The following is a description of a gene set: from publication Lee MS, Hanspers K, Barker CS, Korn AP, McCune JM (PMID 15210650) Human Gene Set: LEE_EARLY_T_LYMPHOCYTE_UP studied in species Homo sapiens Genes up-regulated at early stages of progenitor T lymphocyte maturation compared to the late stages. To develop a comprehensive catalogue of phenotypic and functional parameters of human CD4(+) T cell differentiation stages, we have performed microarray gene expression profiling on subpopulations of human thymocytes and circulating naive CD4(+) T cells, including CD3(-)CD4(+)CD8(-) intrathymic T progenitor cells, CD3(int)CD4(+)CD8(+) 'double positive' thymocytes, CD3(high)CD4(+)CD8(-) 'single positive' thymocytes, CD3(+)CD4(+)CD8(-) CD45RA(+)CD62L(+) naive T cells from cord blood and CD3(+)CD4(+)CD8(-) CD45RA(+)CD62L(+) naive T cells from adult blood. These subpopulations were sort-purified to >98% purity and their expressed RNAs were analyzed on Affymetrix Human Genome U133 arrays. Comparison of gene expression signals between these subpopulations and with early passage fetal thymic stromal cultures identify: (i) transcripts that are preferentially expressed in human CD4(+) T cell subpopulations and not in thymic stromal cells; (ii) major shifts in gene expression as progenitor T cells mature into progeny; (iii) preferential expression of transcripts at the progenitor cell stage with plausible relevance to the regulation of expansion and differentiation of these cells; and (iv) preferential expression of potential markers of recent thymic emigrants in naive-phenotype CD4(+) T cells from cord blood. Further evaluation of these findings may lead to a better definition of human thymopoiesis as well as to improved approaches to monitor and to augment the function of this important organ of T cell production., and this is the list of marker genes: CEP128, TSHR, UBE2C, OIP5, TYMS, PRR11, BUB1, RUFY3, CD1A, RAG1, PON1, E2F8, MZB1, CDCA2, SGO2, DTL, KIF14, KIF2C, MCM4, MKI67, DLGAP5, AEBP1, KIF15, NDC80, CCNB2, TMSB15A, GSE1, CD1B, HMMR, GNA15 (NCBI Gene Id 2769), GFI1, GINS1, LDLRAD4, MIR646HG, KIF20A, NUSAP1, CD99, GIHCG, HHIP, TOP2A, KIF18B, UHRF1, NEK2, PBK, NEIL3, ATAD2, CENPU, CDK1, CENPA, CENPW, MYB, CXXC5, DNTT, CDKN3, LRR1, PRC1, FAIM, GALNT7, CEP70, KNL1, UBE2T, SCRN1, LETM1, CDC25A, TUBB4B, SYK, CKS2, BIRC5 (baculoviral IAP repeat containing 5), BUB1B, NLGN4X, RAPGEF5, MCM10, DIAPH3, CCNB1, TTK, FANCI, PCLAF, NCAPG, KIF11, ADA, MPP1, NSD2, HELLS, CRNDE, GGH, RCAN1, PALLD, TUBB, TFDP2, CPVL, CDCA3 (cell division cycle associated 3), HMGB3, FAM72C, PTTG1, E2F7, RAD51AP1, ASPM, AURKA, DSCC1, ARPP21, E2F2, RRM2, MELK, MCM2, PALM2AKAP2, CD1E, NUF2, CEP55, SLC1A4, TNFRSF21